The following is a description of a gene set: from publication Chen Y, Wang X (PMID 31504780) species: Homo sapiens Human Gene Set: MIR361_5P Genes predicted to be targets of miRBase v22 microRNA hsa-miR-361-5p in miRDB v6.0 with MirTarget v4 prediction scores > 80 (high confidence targets)., and this is the list of marker genes: EFHC2, GOLGA4, NFE2, CCDC169-SOHLH2, KCNJ3 (potassium inwardly rectifying channel subfamily J member 3), MEF2D (myocyte enhancer factor 2D), SLC24A2, SOWAHC, ANKRD33, SLC66A1LP, STARD5, DEXI, CAPN6, TET1, SEC31A (SEC31 homolog A, COPII coat complex component), WARS2, CYP2U1 (NCBI Gene Id 113612), VEGFA, MAP2, FUT9, TET2, YIPF4, UTP15, MIX23, SLCO6A1, ERC2, PLD1, CKS1B, ZDHHC13, CDYL2, ZNF460, TSR1, DCTN6, NAALAD2, HOMER1, LACTB, ENDOD1, PABPC4L, STEAP2, KLHL7, PABIR3, DOK6, ARGLU1, PDE4B (NCBI Gene Id 5142), OGN, SYNCRIP, DR1 (NCBI Gene Id 1810), WDHD1, C2orf78, PANX2, XRCC4 (NCBI Gene Id 7518), RAC1, USP44, MERTK, SERP1, GSTA2, ERCC6, GSTA1, GPR155, SLC39A9, ZNF804A, HOOK1, MTX3, ZNF492, SMG1, RDH11, NIPSNAP3B, ADAM18, ZNF510, FGF7, TIPIN, GAPT, RAB28, INTS8, SYT10, CCDC178, ZBTB40, HSP90AA1, GNA13, ZNF148 (NCBI Gene Id 7707), ZSCAN32, CPOX, LURAP1L, BTF3, ABCB10, NXPH2 (NCBI Gene Id 11249), PCGF5, RNF11, MTRR, KPNB1, RNF4, CNTN1, SDCBP, UGT2A3, PCYOX1, SLC10A1, HFE, CDC123, CSTF1, BLMH, CCNYL1, FKBP14, SCAF8, PDE4D, ZNF160, EDIL3, WNT3, MECP2, ZBTB18, RRAGB, ZMAT3, ZNF516, CCDC28A-AS1, RANBP17, FGF5, CAB39L, MEX3C, CREBBP, COPS7A, RAG1, GEN1, C6orf58, AWAT2, CLDN22, PROSER3, RHOA, PIK3CG, PARP11, C12orf50, NFAT5 (NCBI Gene Id 10725), AAK1, MAP10, ANO6, CSMD1, CDS1, GLRB, LGR4, RAB3GAP1 (NCBI Gene Id 338380), OPTN, ELMOD1, THUMPD1, NR4A2, PCDHB4, DERL2, ATPAF1, ATAD1, PRICKLE2, PLPPR4, BMPR2, ELL3, WNT7A, ELOVL7, TFAP2B, ABHD3, CREG1, ARRDC3, AK5, EIF3A, SP1, CSNK1G3, PROX1, DYNC1LI2